The following is a description of a gene set: The chemical reactions and pathways resulting in the formation of mineralocorticoids, hormonal C21 corticosteroids synthesized from cholesterol. Human Gene Set: GOBP_MINERALOCORTICOID_BIOSYNTHETIC_PROCESS species: Homo sapiens, and this is the list of marker genes: DAB2, CLCN2, DKK3, BMP6, REST, CACNA1H, BMP2, CYP11B1, CYP11B2, BMP5, CYP21A2, WNT4